The following is a description of a gene set: Mouse Gene Set: BURTON_ADIPOGENESIS_PEAK_AT_24HR from publication Burton GR, Guan Y, Nagarajan R, McGehee RE Jr (PMID 12137940) species: Mus musculus The molecular mechanisms that regulate cellular differentiation during development and throughout life are complex. It is now recognized that precise patterns of differentially expressed genes ultimately direct a particular cell toward a given lineage and many of these are regulated during the earliest stages of differentiation. Using a microarray-based expression analysis, we have examined gene expression profiles during the first 24 h of 3T3-L1 adipocyte differentiation. RNA was isolated at times 0, 2, 8, 16, and 24 h following stimulation of differentiation and hybridized in duplicate to high density Affymetrix microarray gene chips containing a series of 13,179 cDNA/expressed sequence tag (EST) probe sets. Two hundred and eighty-five cDNA/ESTs were shown to have at least a fivefold change in expression levels during this time course and both hierarchical and self-organizing map clustering analysis was performed to categorize them by expression profiles. Several genes known to be regulated during this time period were confirmed and Western blot analysis of the proteins encoded by some of the identified genes revealed expression profiles similar to their mRNA counterparts. As expected, many of the genes identified have not been examined in such a critical time period during adipogenesis and may well represent novel adipogenic mediators. Cluster 5: genes progressively up-regulated (peak at 24 h time point) during differentiation of 3T3-L1 fibroblasts into adipocytes in response to adipogenic hormones., and this is the list of marker genes: Gm4870, Agt, Kif20a, Bbln (bublin coiled coil protein), Ccnb1, Srsf1, S100a8, Aurkb, Kpna2, Cenpl, Rrm1, Racgap1, Cdk1, Elavl1, Prc1, Exosc5, Trappc5, Kifc5b, Hmmr, Slpi, Ly6c1 (lymphocyte antigen 6 family member C1), Ube2c, Anln, Pttg1 (NCBI Gene Id 98125), Stmn1, Anxa8, Prl2c2, Galk1, Top2a, H2ax, Nusap1, Kif22, Cbr2, Ccna2 (cyclin A2), Lcn2, Snrnp70, Isyna1, Wfdc12, Bub1, Tk1, Aqp1, Dctpp1, Melk, Cad, Rangap1, Cdc25c, Ipo5, Ly6a, Cdc20